The following is a description of a gene set: part of: Signaling by Rho GTPases studied in species Homo sapiens RHO family of GTPases is large and diverse, with many of its members considered to be master regulators of actin cytoskeleton. RHO GTPases are involved in the regulation of many cellular processes that depend on dynamic reorganization of the cytoskeleton, including cell migration, cell adhesion, cell division, establishment of cellular polarity and intracellular transport. As a consequence, RHO GTPases play important roles in neuronal development, immunity and cardio-vascular homeostasis. RHO GTPases are involved in the etiology of infectious diseases, congenital immunodeficiencies, neurodegenerative diseases and cancer. For review, please refer to Jaffe and Hall 2005, Lemichez and Aktories 2013, Ridley 2015, Hodge and Ridley 2016, Haga and Ridley 2016, Olson 2018, and Kalpachidou et al. 2019.<br><br>Phylogenetically, RHO GTPases can be grouped into four clusters. The first cluster consists of three subfamilies: Rho, RhoD/RhoF and Rnd. The second cluster consists of three subfamilies: Rac, Cdc42 and RhoU/RhoV. The third cluster consists of the RhoH subfamily. The fourth cluster consists of the RhoBTB subfamily. Miro GTPases and RHOBTB3 ATPase are sometimes described as Rho family members, but they are phylogenetically distant from the Rho family and constitute two separate families of Ras-like GTPases, which, besides Rho, Miro and RHOBTB3 also includes Ran, Arf, Rab and Ras families. Based on their activation type, RHO GTPases can be divided into classical (typical) and atypical. Classical RHO GTPases cycle between active GTP-bound states and inactive GDP-bound states through steps that are tightly controlled by members of three classes of proteins: (1) guanine nucleotide dissociation inhibitors or GDIs, which maintain Rho proteins in an inactive state in the cytoplasm, (2) guanine nucleotide exchange factors or GEFs, which destabilize the interaction between Rho proteins and their bound nucleotide, the net result of which is the exchange of bound GDP for the more abundant GTP, and (3) GTPase activating proteins or GAPs, which stimulate the low intrinsic GTP hydrolysis activity of Rho family members, thus promoting their inactivation. GDIs, GEFs, and GAPs are themselves subject to tight regulation, and the overall level of Rho activity reflects the balance of their activities. Many of the Rho-specific GEFs, GAPs, and GDIs act on multiple Rho GTPases, so that regulation of these control proteins can have complex effects on the functions of multiple Rho GTPases. The classical Rho GTPase cycle is diagrammed in the figure below. External or internal cues promote the release of Rho GTPases from the GDI inhibitory complexes, which allows them to associate with the plasma membrane, where they are activated by GEFs (1), and can signal to effector proteins (4). Then, GAPs inactivate the GTPases by accelerating the intrinsic GTPase activity, leading to the GDP bound form (2). Once again, the GDI molecules stabilize the inactive GDP bound form in the cytoplasm, waiting for further instructions (3). Classical RHO GTPases include four subfamilies: Rho (includes RHOA, RHOB and RHOC), Rac (includes RAC1, RAC2, RAC3 and RHOG), Cdc42 (includes CDC42, RHOJ and RHOQ) and RhoD/RhoF (includes RHOD and RHOF). RHOA, the founding member of the RHO GTPase family, regulates the actin cytoskeleton, formation of stress fibers and cell contractility, which is implicated in cell adhesion and migration. RHOB and RHOC functions resemble RHOA. RHOB is also involved in membrane trafficking and DNA repair. RAC1 regulates the cytoskeleton and the production of reactive oxygen species (ROS), and is involved in cell adhesion and cell migration. RAC2 expression is restricted to hematopoietic cells and RAC2 is a component of the phagocytic oxidase complex in neutrophils. RAC3 shares 92% sequence identity with RAC1 and is highly expressed in neurons (de Curtis 2019). CDC42 regulate the cytoskeleton and cell polarity, and is involved in cell adhesion and migration as well as in intracellular membrane trafficking. RHOJ is highly expressed in endothelial cells, regulating their motility and vascular morphogenesis. RHOQ (also known as TC10) is highly activated on exocytosing vesicles and recycling endosomes and is involved in trafficking of CFTR (cystic fibrosis transmembrane conductance regulator). RHOD regulates cytoskeletal dynamics and intracellular transport of vesicles. RHOF regulates cytoskeletal dynamics and promotes the formation of filopodia and stress fibers. RHOD and RHOF do possess GTPase activity and are therefore grouped with classical RHO GTPases, but they are atypical in the sense that they possess high intrinsic guanine nucleotide exchange activity and do not require GEFs for activation.<br><br>Atypical RHO GTPases do not possess GTPase activity. They therefore constitutively exist in the active GTP-bound state. Atypical RHO GTPases include three subfamilies: Rnd (includes RND1, RND2 and RND3), RhoBTB (includes RHOBTB1 and RHOBTB2), RhoH (RHOH is the only member) and RhoU/RhoV (includes RHOU and RHOV). RND1 and RND3 can antagonize RHOA activity, leading to loss of stress fibers and cell rounding. RND1, RND2 and RND3 regulate cell migration. RHOBTB1 is a component of a signaling cascade that regulates vascular function and blood pressure. RHOBTB2 is involved in COP9 signalosome-regulated and CUL3-dependent protein ubiquitination. RHOH expression is restricted to hematopoietic cells, and it is known to be involved in T cell receptor (TCR) signaling and T cell development. RHOU and RHOV expression is induced by WNT signaling and they are involved in regulation of cell shape and cell adhesion.<br><br>Almost every classical RHO GTPase interacts with multiple GEFs, GAPs and GDIs, and every RHO GTPase activates multiple downstream effectors. There are 82 Rho GEFs (71 Dbl, reviewed in Fort and Blangy 2017, and 11 DOCK, reviewed in Meller et al. 2005), 66 Rho GAPs and 3 Rho GDIs encoded by the human genome. To keep our reaction annotations compact, we have grouped the GEF, GAP, GDI and effector proteins associated with each RHO GTPase into sets. Within a set, we have distinguished full set members from candidate members on the basis of the amount of experimental evidence supporting the member’s molecular function. Note that members of a set can otherwise be functionally quite diverse. Reactome Pathway: RHO GTPase cycle, and this is the list of marker genes: DIAPH1, PLXNB1, HSPE1 (heat shock protein family E (Hsp10) member 1), GIT1, ALDH3A2, RND3, LMNB1 (NCBI Gene Id 445266), ARHGEF18 (NCBI Gene Id 85008), PIK3CA, ABCD3, MCF2L, SRC, TAOK3, MTR, DOCK9, VAV2, CPD, ARHGDIB (Rho GDP dissociation inhibitor beta), STK10, POTEE, NOX3, GJA1 (NCBI Gene Id 7953), SLC1A5, BCAP31, HINT2, ARHGEF25, DOCK11, SENP1, CHN2 (NCBI Gene Id 644086), LETM1, WASF3, FAM13A, PLEKHG1, WIPF3, CKB, PLEKHG2, TMPO (NCBI Gene Id 7112), STIP1, TFRC (NCBI Gene Id 7037), ARHGAP33, KIDINS220, ARHGAP6, FARP1 (FERM, ARH/RhoGEF and pleckstrin domain protein 1), ARHGAP44, ARHGAP23, TAGAP (T cell activation RhoGTPase activating protein), TMEM59, CIT, USP9X, ARAP1, C1QBP, TOR1AIP1, GOPC, MTX1, BAIAP2, IQGAP3, BLTP3B, ARHGEF12, SRGAP1, GOLGA8R, AKAP12, IQGAP1, LAMTOR1, ARHGEF9, ARHGAP15, STK38, STAM2, FGD5, SH3RF1, SCRIB, PKN1, CDC42BPA, RHOBTB2, DOCK1, RHOU, VCP, ARHGEF15, CFTR, GMIP, OSBPL11, CCP110, CYBB, ARHGEF3, RHOQ, NGEF (NCBI Gene Id 25791), ARAP3, HNRNPC, FERMT2, TNFAIP1, TEX2, DBT, PKN3, RALGAPA1, PLD1, PLXNA1, WDR6, ROCK1, MUC13, ZAP70, ARHGEF6, RHOJ (NCBI Gene Id 57381), ARHGAP11A, DOCK4, FAM83B, RHOV, COPS2, ARFGAP3, ARHGEF40, WIPF2, SYDE2, VMA22, VAV3, ITSN1, PCDH7, LCK, SLK, SPTAN1, NCF1, KCTD3, CAVIN1, ACTC1, DEPDC1B, CUL3, ARHGAP1, FGD3, TWF1 (NCBI Gene Id 82712), ABI1, PIK3R2 (NCBI Gene Id 5296), DOCK10, MOSPD2, RHOB, RALBP1, ABR, ARHGEF10L, ARHGAP8, CCDC187, DOCK6 (NCBI Gene Id 57572), CDC42, RHOBTB1, ACBD5 (NCBI Gene Id 91452), MTMR1, SAMM50, FMNL1 (formin like 1), KIF14, ARHGAP18, HGS, CSK (C-terminal Src kinase), WWP2, ARHGAP19, WAS, ARHGAP17, PLEKHG4B, SHKBP1, CYBA, HMOX2, VIM, ARHGAP27, GARRE1, SPATA13, NDUFS3 (NCBI Gene Id 4722), GRB7, WDR81, GNA13, WASL, FMNL3, MYO6, TRIP10, TIAM1, DIAPH2, RAC2, FGD2, KCTD13, PREX2, PICALM, OPHN1, ARHGAP20, BASP1, CDC42EP5, ARHGAP5, BRK1, PREX1, SYDE1, PAK6, ARHGAP4, STMN2, ARHGAP26, TMOD3, NCKAP1, RTKN, TMEM87A, KALRN, CHN1, ARHGAP32, ARHGAP45, SLITRK5, PGRMC2, PIK3R1, VAV1, RND1, SCFD1, EPSTI1, DAAM1, DSG1, NOXO1 (NCBI Gene Id 124056), CCT7, NDUFA5, GIT2, WASF2, SNAP23, FILIP1, FRS3, SRGAP2, PIK3R3, PHIP, DST, NSFL1C, ABL2, ABI2, WASF1, STAM, ARFGAP2, ARHGAP24, PAK5, ARHGAP25, ARHGEF2, DDX39B (NCBI Gene Id 7919), PARD6B, CDC42EP2, SLC4A7, RHPN1, ANKLE2, ZNF512B, PKN2, CEP97, SEMA4F, ARHGEF5, ARHGEF7, HSP90AA1, ARHGAP11B, CKAP4 (cytoskeleton associated protein 4), RBBP6, GFOD1 (Gfo/Idh/MocA-like oxidoreductase domain containing 1), PLEKHG5, STX5, TJP2, SH3BP1, ACTG1, PDE5A, RNF20, RRAS2, SWAP70, PARD6A, DIAPH3, RHOG, ACTB, ARHGAP10, NUDC, PTPN13, STARD13, RHOD, FLOT2, GRB2 (NCBI Gene Id 80715), CCT6A, VAPB, SOS2, VRK2, ARHGEF19, NCKAP1L, CDC42BPB, VANGL1, SRRM1, TUBA1B, PRAG1, JAG1, KTN1, CDC42EP3, DBN1, SOWAHC, ARHGAP40, ARHGAP12, NCK1, ARHGEF16, ARHGEF39, TPM3, ARHGAP39, CCDC88A, FAF2, RND2, ARHGDIG, VANGL2, ELMO2, ARMCX3, AKAP13, RHOF, WDR91, ARHGAP22, ITGB1, HSP90AB1, ACTN1, FRS2, BAIAP2L2, EPHA2, RAC1, PAK3, PAK4, FARP2, ANKRD26, CDC42EP1, ARHGAP30, SHMT2, IL32, VAMP3, PLEKHG3, EMC3, RACGAP1, FAM169A, DLC1, RASGRF2 (NCBI Gene Id 89993), ARHGDIA, YKT6 (NCBI Gene Id 63236), ARHGAP9, BAIAP2L1, ARHGAP42, NCF2, PAK2, ERBIN, ANKFY1, UBXN11, PAK1, ARHGEF4, RHOH, FLOT1, NOXA1, MYO9B, DSP, STARD8, OBSCN, LMAN1, ARHGEF17, ALS2, TRIO, RHOA, RHOC (ras homolog family member C), GPS1, NIPSNAP2, ARHGEF10, PLD2, EFHD2, DLG5, ESYT1, FMNL2, PLEKHG4, ARHGAP21 (Rho GTPase activating protein 21), STBD1, JUP, CYFIP2, NCF4, FGD4, SOS1, SPEN, FNBP1L, WHAMM, ROCK2, ARHGAP35, FAM135A, SH3PXD2A, PTK2B, SLITRK3, FNBP1, WDR11, IQGAP2, SRGAP3, CCT2, UACA, RHPN2, ECT2, CPNE8, PKP4, ARHGAP29 (NCBI Gene Id 9411), MYO9A, CDC37, PLEKHG6, SPTBN1 (spectrin beta, non-erythrocytic 1), MPP7, NET1, DNMBP, RAB7A, DOCK5, MCAM, WIPF1, AMIGO2, NISCH, DDX4, LRRC1, ARAP2, CPSF7, TRA2B, RAC3, MACO1, NOX1, ARHGEF1, DOCK8, MAP3K11, CDC42SE2, DSG2, RBMX, ARHGAP31, FAM91A1, ARHGEF26, GOLGA3, COPS4, STEAP3, ARHGEF28 (NCBI Gene Id 64283), LEMD3, NCK2, AAAS, CAPZB, DEF6, ARL13B, MSI2, CLTC, ARHGAP28, DOCK7, RASAL2, CYFIP1, DDRGK1, FGD1, TPM4, ITSN2, STOM, DOCK2, ADD3, OCRL, PLXND1, ARHGEF11, RAPGEF1, LBR, CDC42EP4, FAM13B, TXNL1, ANLN, DOCK3, BCR, EMD, ATP6AP1, NHS, PEAK1, CAV1, TIAM2, MCF2